Given this list of marker genes ATP6V1F, TSC22D4, CA7, DNAJB2, ATP7A, ATP6V0A1, ATP6V1G2, CHMP2B, CX3CL1, OSBPL2, HEXB, ATP6V1E1, IFNB1, TAOK1, ATP6AP2, PRKAA1, PSEN1, SLC6A2, ATP6V1G1, SV2B, TMEM106B, ATP2B3, BAP1, ATP6V1B2, DCTN1, ATP6V1B1, CNR1, P2RY1, ERC2, ATP6V1A, ATP6V0C, NPY, SLC8A2, DISC1, CA2, TYRO3, ATP2A2, ATP6V1D, CALB2, IL6, ATP6AP1, TMEM175, IMMT, ATP6V0D1, CHRNA1, ATP6V0A4, HAAO (NCBI Gene Id 23498), ATP6V1C1, MAP1A (NCBI Gene Id 4132), FGGY, NELL2, ATP6V1G3, CALB1, ADORA1, SLC24A2, TSPOAP1, CLCN3, P2RX1, SLC17A7 (NCBI Gene Id 57030), PRKN, CACNB2, CACNB4, AIM2, SNAPIN, here is a description of the gene set: studied in species Homo sapiens Human Gene Set: GOBP_NEURON_CELLULAR_HOMEOSTASIS The cellular homeostatic process that preserves a neuron in a stable, differentiated functional and structural state.